Given this list of marker genes RPTOR, LARP1, AKT1S1, TTI1 (TELO2 interacting protein 1), MTOR, MLST8 (NCBI Gene Id 64223), here is a description of the gene set: Human Gene Set: GOCC_TORC1_COMPLEX A protein complex that contains at least TOR (target of rapamycin) and Raptor (regulatory-associated protein of TOR), or orthologs of, in complex with other signaling components. Mediates the phosphorylation and activation of S6K. In Saccharomyces, the complex contains Kog1p, Lst8p, Tco89p, and either Tor1p or Tor2p. studied in species Homo sapiens